The following is a description of a gene set: Human Gene Set: GSE37301_CD4_TCELL_VS_RAG2_KO_NK_CELL_DN Genes down-regulated in CD4 T cells versus RAG2 knockout NK cells. from publication Ramirez K, Chandler KJ, Spaulding C, Zandi S, Sigvardsson M, Graves BJ, Kee BL (PMID 22608498) species: Homo sapiens Expression profiling of Rag2-deficient Ets1++ and Rag2-deficient Ets1-- mature NK cells and WT bone marrow progenitors, WT T cells, and WT Pro B cells, and this is the list of marker genes: NLN, SLC37A4, ZBTB8A, TPPP, NQO2, VRK1, RPS6KA5, SERINC5, PACS1, PTPN9, CCDC112, GNAQ, SYNRG, GPX1, YWHAB, GPAT3, IQCE, IRAK3, BMPR2, HSPBAP1, GLT8D1, RIPK1, EIPR1, BUD13 (NCBI Gene Id 84811), APLP1 (NCBI Gene Id 333), LTB4R, COX7A2, POMT2, DNASE1L1, SEC24D, SECISBP2L, TSC22D1, KIT, LGALS3 (galectin 3), RNF169, ERCC6, REEP5, TTC17, LIG4, MMP25, MID1IP1, GATA3, VAV2, DOCK5, EML4, SLC25A20, ATP13A3, FAM114A1, RRBP1, EIF1, ITGA1, ACLY, ZBTB32, ATP10D, ATP8A2, CASP6, YIPF1 (NCBI Gene Id 54489), SNUPN, SNX29, LPCAT2 (NCBI Gene Id 54947), PROS1, MARCHF8, NPNT, EMP1, CACNB1 (calcium voltage-gated channel auxiliary subunit beta 1), OTUD5, HERPUD2, GZMB, PCDH19, MON1A, EHMT1, PLEKHO2, RAP2A, BPGM, ACAP3, SLFN5, GM2A, ABCB10, SLC49A4, CHST11, LMNA, GALNT1, CD44, ITPRIPL1, IGFBP7, EEF2K, GPR158, FAH, ERLIN2, TMTC2, QSER1, NEB, SOAT1, EGR1, VIM, RALBP1, FZD7, DTNB, ZCCHC24, SP6, ADIPOR2, ATP6V0E1, MRPS21, ARID1B, FOS, E2F5, DIP2A, SWAP70, CAPN2, PI4K2A, TRAPPC14, CAPG, CPEB2, LPIN1, BRAF, COBLL1, ANKRD6, PLEC, TLN1, ITPRIPL2, SQOR, DFFA, NDRG1, JUP, ARHGAP23, SLC44A1, EZR, KLF7, EIF3I, ATP6V0A1, OSBPL1A, MITF, SDHC, PDCD6, PPP1R3F, OSBPL7 (NCBI Gene Id 54871), AP2M1, TMBIM6, SPATA13, STIM1, TNRC6C, LPCAT3, LAMC1, RCOR1, DOP1B, MYADM, PRKAR2B (protein kinase cAMP-dependent type II regulatory subunit beta), GLUL, NCOR1, S100A13, PLXNA1, KMT2C, MGAT4B, ETV5, GPD2, MTOR, SNX9, SLC41A2, ADCK2, SOCS2, PSEN2, FBXO30, DUSP7, TATDN2, PDP1, KAT6A, EMC3, CLTB, KDM4B, TACC1, MIB1, SEC16A, TAF9B, HECTD3, ELMO2, SH3GLB1, TMOD3, HPGD, ST3GAL2, NCOA1